The following is a description of a gene set: Human Gene Set: GOBP_REGULATION_OF_TRIGLYCERIDE_CATABOLIC_PROCESS Any process that modulates the frequency, rate, or extent of the chemical reactions and pathways resulting in the breakdown of triglyceride. species: Homo sapiens, and this is the list of marker genes: APOC2, PNPLA2, PIK3CG, APOC3, APOA5, FUT1, DAGLB, AADAC, APOC1 (apolipoprotein C1), GPLD1, SORL1, PLIN5, APOA4, ABHD5